Given this list of marker genes Uba52, Psmc2, Psmc6, Nfkbia, Ubc, Psmd12, Psmd14, Nfatc2 (NCBI Gene Id 99036), Psmd1, Psmb6, Psmb2, Psmd6, Kras, Prkcb, Psma1, Ppp3cb, Psmb4, Psmb3, Nfatc1 (nuclear factor of activated T cells, cytoplasmic, calcineurin dependent 1), Psma2, Psmd2, Fbxw11, Ppp3r1, Ubb, Psmb5, Psmc4, Psma3, Malt1, Chuk, Ikbkb, Psmd11, Bcl10, Ikbkg, Uba52rt, Fkbp1a, Nfatc3, Rela, Nfkbib (nuclear factor of kappa light polypeptide gene enhancer in B cells inhibitor, beta), Nfkb1, Psma4, Potefam3d, Psma6, Card11, Psma7, Psmd8, Calm1, Potefam3c, Hras, Cul1, Adrm1 (NCBI Gene Id 99832), Psmb1, Psmc1, Psmd13, Psmc3, Calm2, Ppp3ca, Psmc5, Rasgrp3, Psma5, Rps27a, Rasgrp1 (RAS guanyl releasing protein 1), Psmb7, Skp1 (S-phase kinase-associated protein 1), Calm3, Psmd3, Rel (reticuloendotheliosis oncogene), Psmd7 (proteasome (prosome, macropain) 26S subunit, non-ATPase, 7), here is a description of the gene set: species: Mus musculus Downstream signaling events of B Cell Receptor (BCR) Mouse Gene Set: REACTOME_DOWNSTREAM_SIGNALING_EVENTS_OF_B_CELL_RECEPTOR_BCR